Given this list of marker genes IBTK, CHMP4B, TNFSF10, PVALB, CORO2B, ANKRD17, CYP51A1, NUPR1, SLC12A4, EIF2B5, PAXBP1, SPRED2, FNBP1, TES, IL4, TTC39B, CLN8, ADAM8, MAPK6, SRGN, TEX2 (testis expressed 2), RGS10, TWF1, EIF1AY, TGFB1, EMP1, UGP2, PPP1R2P1, PDK3, SELENOS, MIA3, ST6GALNAC4 (ST6 N-acetylgalactosaminide alpha-2,6-sialyltransferase 4), FOSL1, CCL1, LGALS8, FKBP10, APBB1IP, SCMH1, KCNA3, ADPGK, CCL7, CSF1, CLDND1, RPIA, DUSP6, PTPN6 (NCBI Gene Id 5777), FDFT1, AGFG1, PTH, NRAS, FURIN, TMED7, CXCL3, F7, CYTH2, EEA1, PLA2G5, SMS, M6PR, POU2F2, LCP2, HSD17B12, PCNT, ACTG2, ERO1A, SLC4A7, MPO, IDI1, TRAF1, GAL, SPP1, NUMB, SRP19, ZC3H12C, HCCS, SEPTIN11, MAFB, MSMO1, FHL2, TMEM229B, STK19, PHLDA1, ALCAM, ZAP70, F2RL3, CSNK1E, ABCD4, PTK2B, RSAD2, RRS1, TBRG1, BTG1, KLRG1 (killer cell lectin like receptor G1), SUB1, HMGCR, GEM, RYR3, GCH1, PLG, ESF1, GTPBP4, DAXX, LAMC1, IL10, EXOSC7, ELL2, NCKAP1, TNFSF11, NMD3, IKZF4, FNDC3A, STT3B, ACSL4, CMTR2, PNPT1, LDLR, NAMPT, MMP11, SLC25A47, SERPINB9, SLFN12L, CYTIP, CRCP, GNG12, ASS1, SH2D2A, IFIT1B, IL6, SOD3, NUDCD2 (NudC domain containing 2), CACNG1, TSR1, DNAAF5, IGSF8, TNF, PRKCE, CD44, RFLNB, TFCP2L1, CITED2, ECE1, TOR1B, SLC2A3, TBRG4 (NCBI Gene Id 9238), HMGCS1, SUN1, TLE3, SYPL1 (NCBI Gene Id 6856), ALDH7A1, MAPK8, ISG20, PIM3, CPD, MYH3, ITK, EPB41L4A-AS1, ZFPM1, ATF6, TRAF5, SLC16A1, PTPRR, CFLAR, TXNDC17, TSPAN5, PTPN22, LRBA, CD247 (CD247 molecule), PALD1, HBEGF (NCBI Gene Id 1839), CASP3, SLC1A5, SLC20A1, RBMS1, IL5, MYH8, UBE2V2, CAPRIN2, CD82 (CD82 molecule), CFD, SQLE, BCL2A1, TMEM45A, CD68, AREG, IL13, NCOA5, ACP3, CCNC, APLN, EIF1, CCND2 (cyclin D2), DHX32, TOLLIP, NSMF, PITPNC1, CCR1, COMT, NOCT (NCBI Gene Id 25819), NDRG1, here is a description of the gene set: Human Gene Set: GSE19923_E2A_KO_VS_HEB_AND_E2A_KO_DP_THYMOCYTE_UP studied in species Homo sapiens Genes up-regulated in double positive thymocytes: TCF3 knockout versus TCF12 knockout. We wanted to test the role of mammalian E proteins E2A and HEB in the development of T cells. Using a conditional deletion system in which these proteins are deleted at the DP stage of T cell development, we compared DP thymocytes deficient for E2A, HEB or both to wild-type thymocytes from publication D'Cruz LM, Knell J, Fujimoto JK, Goldrath AW (PMID 20154672)